The following is a description of a gene set: Human Gene Set: MIR409_3P Genes predicted to be targets of miRBase v22 microRNA hsa-miR-409-3p in miRDB v6.0 with MirTarget v4 prediction scores > 80 (high confidence targets). from publication Chen Y, Wang X (PMID 31504780) species: Homo sapiens, and this is the list of marker genes: THOC2, UBE2W, EML5, NFKBIZ, ZNF704, SERPINA10, LRRN4CL, IFTAP, CHM, ZNF781, SALL1, ZZZ3, MTRR, TSPYL1, DCLRE1B, ZNF99, ATF7, ITGB3, EPHA7, SEC22B, KLF5, LMO4, CACNB4 (NCBI Gene Id 785), NXPH1, GRHL3, VPS41, FAM120A, NUFIP2, CPSF6, NAV2, DENND2C, DLG1, SCHIP1, OXTR, AKIRIN1, RAB30, HYCC2, ZNF660, RRH, TRIM33, STRN, REPS1, NEXMIF, TEP1, SAV1, ELF2, CPT1A, USP38, DENND5A, IQCJ-SCHIP1, LANCL2, ASAP2, RCOR2, KLF15, SLC1A3, BTN2A1, AIDA, ZNF138, NPC2, MRPL57, SMAD2, ANAPC7, ZIM2, ZDHHC20, GUCY1A2, EBAG9, SLC15A4, IMPACT, MTF2, NUDT21, RAB10, RORB, KANSL1, SLC35A3, CEP19 (centrosomal protein 19), RBM46, ZNF540, DLL4, VSTM2A, PLCH2, GALNT1, UPK1B, ABHD5, YTHDF3, TM4SF18, TOP2B, FGF3, PDHX, IFIT2, KRTAP7-1, MYO1D, PPP2R5E, CPD (NCBI Gene Id 1362), NAA15